Given this list of marker genes TAF12, MSI2, LRRC19, SMOC2, CDH6, AFG2A, CERS6, NALF2, TMEM70, SRP19, TMTC2, NRAS, MARCHF3, CD1E, TRABD2B, SMIM7, PEX19, HDHD2, CD34, CSNK2A1, KCNIP2, PCDH9, STAU1, WDHD1, NFATC3, NKD1, SULF1, ICAM1, TRMT10A, FRYL, CCR1, FOXM1, NEMP1, TANC2, SGMS1, DLG2 (discs large MAGUK scaffold protein 2), SH2B3, GPR15LG, PLXNA4, ARID5B, ELAVL1, GTF3C4, MTM1, TNK2, ODR4 (NCBI Gene Id 54953), AMHR2, GPRC5B, TANGO6 (transport and golgi organization 6 homolog), MYO1C, PTGS1, UBXN10, PPP1R8, THY1, KLHL24, CYB5D1, GRAP (NCBI Gene Id 112268188), FAM120C, ZNF343, MGA, HMGXB4, CHCHD3, H2BW1, SDK1, DNMT3A, DSC3, CTNND1, MIEF1, LAIR1, WIF1, EYA3, ZNF80, STX2, PRSS23 (NCBI Gene Id 11098), TWIST1, ZNF396, PHC3, GMFB, RPL23A, LRP2, SLC22A3, SLC30A4, SDK2, PRX, LRRC10, N4BP2L2, SRL, CFAP68, CYTH3, DDX52, TMEM273, HMGN5, NSL1, DPF2, UVRAG, ETV5, PALM, RNF8, PARP9, PTBP1, SLC35B4, GLB1L, CCDC186, ETS1, DHRSX, OSMR, ANKRD45, PARS2, MECP2, SLC38A2, DAAM2, GRM1, MICAL2, FHIT, JKAMP, SYT2, FAM237A, TGFBI, PFN4, ITGA5, FBXW8, HLA-B, ZNF385B, ZNF268, ZFAND5, DESI1, BRCC3, PSME3, BHLHE40, MYO3B, MAPK1, FGF11, EPHB3, AFF3, MRAS, AGBL3, ZBTB8A (zinc finger and BTB domain containing 8A), DDT, GPD2, FBXO21, C5orf22, FAIM2, KDM5C, NUBPL, NAF1, RBFOX2, SYT7, BBX, SLC24A3, ZNF212, STRADA, TAF1B, TAOK1, EPB41L1, ADGRL1, ARMH3, KRTAP24-1, H6PD, ZNF839, SLC5A12, BSN, MYO15A, SPIN3, USB1, CRB1, KDM2A, METTL25B, USP2, CD40LG, UBE2R2, TFAP2D, HERC4, HLA-A, POU3F2, TAP2, HLA-C, RHOQ, RUNDC3B, IQCB1, RPE65, OTUD1, ADGRE1, EYA2, FNDC3A, PLA2G5, ALCAM, PRKAR1A, TSPAN18, PTPN3, POGZ, DNAJB1, GDAP2, GSPT1, SMURF2, PAX7, MATCAP2, CTSE, STX16, CBLN2, here is a description of the gene set: Human Gene Set: MIR518C_5P Genes predicted to be targets of miRBase v22 microRNA hsa-miR-518c-5p in miRDB v6.0 with MirTarget v4 prediction scores > 80 (high confidence targets). studied in species Homo sapiens from publication Chen Y, Wang X (PMID 31504780)